Given this list of marker genes CCL2, HTR6, BDKRB2, KISS1R, CHRM4, AGTR2, HTR2A, ADRA2A, NPBWR1, PTGDR2, SSTR4, HRH1, PNOC, GAL, GNRHR2, GPBAR1 (NCBI Gene Id 151306), CXCL1, OPN1MW, CCL11, HTR2C, NPW, AVPR1A, ADRA2B, FPR1, TAAR9, OPN1SW, NLN, TAAR5, RHO, CCKAR, TSHR, FPR2, CXCR3, GPR39, CCL22, LHCGR, ACKR3, TAAR1, TAAR3P, P2RY12, HTR4, EDN2, CMKLR1, CCL5, CCR4, ADORA2B, HTR5A, NTS, RXFP4, GPR132, CXCR2, GPR17, PSAP, EDN3, MRGPRD, TRHR, MLN, P2RY11, XCL1, AVPR2, CYSLTR1, ADRB2, MC5R, APP, CGA, GPR31, NPY4R, C5, PPBP, SAA1 (NCBI Gene Id 6288), CXCL8, PTGER3, NPY2R, SST, EDNRA, CCR7, PROKR1, HCAR2, CCL20, HCAR3, HTR1D, GPR35, RXFP2, OPRK1, LPAR6, HRH4, PROKR2, CHRM2, ACKR2, TAAR6, CCL19, KEL, P2RY4, PLPPR3, NPFF, CYSLTR2, CCL13, SUCNR1, S1PR3, F2RL1, TACR2, PROK1, ADRA1B, TAC3, OPN5, NMUR2, TRH, LPAR2, MC3R, PLPPR2, NPB, CXCR6, CX3CL1, ADRA1A, XCL2, INSL3, CCL7, HTR1B (NCBI Gene Id 3351, 5-hydroxytryptamine receptor 1B), MAS1, FFAR1, TSHB, NPS, PTGER1, LPAR1, TAC1, OXGR1, QRFP, CCL17, CCL3L1, GNRH1, CHRM1, PLPPR4, HRH2, MCHR1 (NCBI Gene Id 2847), NPBWR2, NTSR1 (neurotensin receptor 1, NCBI Gene Id 4923), CHRM5, CXCR4, GNRH2, BDKRB1, HTR7, GNRHR, UTS2 (urotensin 2), HTR1F, PRLHR, CCR6, CXCL6, CXCL5, MC2R, ADRB1 (NCBI Gene Id 153), CCL28, GRPR, GPR183, ADORA1, TAAR8, CXCL9, SSTR3, S1PR2, CCR10, NPSR1, LPAR3, S1PR5, PPY, GHSR, KISS1, PTGFR, GRP, PTGER4, HCAR1, POMC, TAAR2 (trace amine associated receptor 2), CXCL2, XCR1, PMCH, FFAR2, MTNR1B, PLPPR5, LHB, F2RL2, C5AR1, CCR8, QRFPR, DRD2, UTS2B, F2, OPRL1, CCRL2, CNR1, BRS3, MT-RNR2, CCR9 (NCBI Gene Id 2851), MC1R, CXCL3, OXER1, OPRM1, NPY, CX3CR1, CCR5, PLPPR1, MTNR1A, GALR1, MCHR2, ACKR1, HCRTR1, SSTR5, EDNRB, CCL23 (C-C motif chemokine ligand 23), CORT, LTB4R2, CCR1 (C-C motif chemokine receptor 1), C5AR2, CXCR1, CCL21, SSTR1, C3AR1, NMBR, P2RY10, KNG1, GPR143, FSHB, GPR68 (G protein-coupled receptor 68), RGR, DRD4, ADORA3, P2RY1, TACR3, HCRT, ADRB3, CXCL12, GPR4, PDYN, GALR2, HCRTR2, S1PR4, NPY5R, GPR65, P2RY6, HTR2B, EDN1, PENK, NPY1R, FFAR3, OXTR, TACR1, CCR2, NPFFR1, GPR37L1, CXCL16, MLNR, PTGDR, OPRD1, XK, CCL27, SSTR2, RLN3, P2RY13, HTR1E, ADORA2A, APLNR, PF4, NMS, ECE2, P2RY14, AVP, CCL3, GPR55, TBXA2R, NMB, ANXA1, PRLH, OPN4, RLN2, PTAFR, NMU, INSL5, OPN3, AGT, CHRM3, CCK, CCL16, GHRL, GPER1, RRH, CCR3, NMUR1, OPN1LW, P2RY2, CXCR5, PROK2, NPFFR2, CCL25, CXCL13, ADRA2C, HRH3, UTS2R, MC4R, GPHA2, GPHB5, AGTR1, LPAR4 (lysophosphatidic acid receptor 4), DRD1, CCL1, CNR2, NTSR2, FSHR, GALR3, DRD3, CXCL11, LTB4R, LPAR5, F2R, HTR1A, GPR18 (NCBI Gene Id 2841), CCL4, GPR37, CCKBR, PTGER2, APLN, RXFP3, ADRA1D, AVPR1B, OXT, RXFP1, FFAR4, F2RL3, PYY (peptide YY), ACKR4, HEBP1, ECE1, S1PR1, FPR3, DRD5, PTGIR, CXCL10, C3, here is a description of the gene set: studied in species Homo sapiens Rhodopsin-like receptors (class A/1) are the largest group of GPCRs and are the best studied group from a functional and structural point of view. They show great diversity at the sequence level and thus, can be subdivided into 19 subfamilies (Subfamily A1-19) based on a phylogenetic analysis (Joost P and Methner A, 2002). They represent members which include hormone, light and neurotransmitter receptors and encompass a wide range of functions including many autocrine, paracrine and endocrine processes. part of: GPCR ligand binding Reactome Pathway: Class A/1 (Rhodopsin-like receptors)